The following is a description of a gene set: Mouse Gene Set: GOBP_REGULATION_OF_MONOATOMIC_ANION_TRANSPORT studied in species Mus musculus Any process that modulates the frequency, rate or extent of the directed movement of anions, atoms or small molecules with a net negative charge into, out of or within a cell, or between cells, by means of some agent such as a transporter or pore., and this is the list of marker genes: Gopc, Rab11b, Abcb1a, Tcaf1, Mtor, Atp8b1, Car2, Stc1, Trpa1, Pdzk1, Ripk1, Prkg2, Car7, Ahcyl1, Abcb1b, Cftr